Given this list of marker genes Emd, Snca, Syne1, Ptgs2 (prostaglandin-endoperoxide synthase 2), Sigmar1, Ugt2b5, Nucb2, Dmpk, Psen1, Retsat, Eno1b, Nav3, Syne2 (NCBI Gene Id 630548), Ugt2b38, Ugt2b1, Dhcr7, Slc22a3, Itpr3, Kash5 (NCBI Gene Id 384619), Eno1, Ltc4s, Smpd4, Itprip, Trappc2b, Syne3, Clmn, Lrpprc, Syne4, Ugt2b37, Nutf2-ps1, Ghrhr, Bok, Cptp, Tmem53, Nutf2, Tmem109, here is a description of the gene set: Mouse Gene Set: GOCC_NUCLEAR_OUTER_MEMBRANE species: Mus musculus The outer, i.e. cytoplasm-facing, lipid bilayer of the nuclear envelope; continuous with the endoplasmic reticulum of the cell and sometimes studded with ribosomes.